Given this list of marker genes Resp18, Ybx1, Mapt, Pde1b, Ephb2, Agrp, Eno2, Bdnf, Rcvrn, Btd, Ptger4, Fmr1, Kcnn4, Homer2, Hspa1b, Plxnd1, Pink1, Igsf9b, Sncb (NCBI Gene Id 98433), Gabbr1, Crhbp, Rogdi, Lypd6, Htr1a, Hnrnpa2b1, Slc6a6, Tac1, Rab5a, Dynlt1c, Rapgef3, Rheb, Htt (NCBI Gene Id 319350), Ctnnd2, Wdr47, Psen1, Syn1 (synapsin I), Siah2, Tiam2, Lrrk2, Kcne3, Brinp1, Hspa8, Actg2, Nr1d1 (nuclear receptor subfamily 1, group D, member 1), Adam10, Gnb1, Cacna1d (NCBI Gene Id 97919), Hcn2, Lsm1, Dip2b, Rasgrf1, Kcnd3, Th (tyrosine hydroxylase, NCBI Gene Id 21823), Eef1a2, Atp6ap2, Erbb4, Mapk8 (mitogen-activated protein kinase 8), Dab1, Ror2, Rufy3, Nap1l4, Mrgpra3, Lamp1, Entpd1, Mtor, Ret, Ngfr, Nefh, Gap43, Zfp385a, Magohb, Pcsk5, Ccng1, Timp2 (tissue inhibitor of metalloproteinase 2), Calca, Kiss1, Grik3, Myo6, Rbp1, Mast1, Ptprz1, Cct4 (NCBI Gene Id 97705), Canx, Wnk4, Cnnm1, Pgrmc1, Lrit3, Rbm8a2, Entpd2, Ass1 (NCBI Gene Id 11898), Cobl, Arpc2, Trpm4, Ntrk1 (NCBI Gene Id 97088), Sh3glb1, Map2k1, Dbn1, Zpbp, Serpine2, Glrx, Enpp1, Glra3, Rack1, Flnb, Ykt6, Ckap5, Clcn2, Apod, P2rx4 (NCBI Gene Id 52272), Slc12a2, Tmem266, Aif1, Ckb, Prkca, Ppargc1a, Gpm6a, Adrb2, Septin4, Atp2b1, Brinp2 (bone morphogenic protein/retinoic acid inducible neural-specific 2), Nlgn3, Tnn, Bace1, Hpca, Gabra5, Epha7, Luzp1, Whrn, Eif5a, Ncam1, Gdi1, Atp1a2, Rbfox3, Atp5mc1, Tpx2, Dynlt1f, Shank2, Srcin1, Slc1a3, Adra2a, Syt11 (NCBI Gene Id 99745), Grm8, Myo10, Gnao1, Cyp19a1, Tlr2, Grik1, Cabp1, Sdc2, Fadd, Snap47, Htr2b, Camk2a, Adora1, Astn2, Kcnc1, Rtn4rl1, Ptpn5, C9orf72, Kif3a, Amfr, Grin3b, Ncdn (NCBI Gene Id 94325), Mbp, Pard3, Lrp4, Snap25, Syt4, Unc5c, Alcam, Nrg1, Hsp90aa1, Crhr2, Gabarapl1, C4b, Cacna1a, Cplx2, Gria1, Gria4, mt-Nd1, Pitpnm3, Ghrh, Drd1, Pnmt, Slc18a2, Kcnk1, Scn1b, Aurka, Slc5a7, Cd200, Gip, Pura, Chrm2, Ntsr1, Rps6-ps4, Ppp5c, Khsrp, Acvrl1, Fzd5, Ubxn1, Pebp1, Acan, Arg1, Cplx1, P2rx7, Ccl2, Kdr, Cacna1e, Cyp11a1, Erbb3, Ezr, Gper1 (NCBI Gene Id 76854), Pmm2, Zpbp2, Cryab, Atp1a3, Rpl28, App, Slc17a8, Klhl1 (kelch-like 1), Rab17 (RAB17, member RAS oncogene family), Katnb1, Elavl4, Igf1, Lrp6, Ptprk, Cnn3, Slc2a13, Ltbp1, P2ry12, Stau1, Rab8a, Pjvk, Nrsn1, Eif4a3, Cpne6, Dlg2, Ang, Psd2, Cit, Txn2, Polr2m, Nrxn1, Slc4a8, Casr, Dixdc1, Slc12a5, Mme, Fbxo31, Dvl1, Rgs7bp, Fbxw11, Ttll7, Dhodh, Podxl, Adam21, Hspa1l, Rab1a, Hcfc1, Cnksr2, S100a5, Slc22a3, Nradd, Pafah1b1, Adcy8, Skor1, Nmnat3, Actc1, Bmpr1b, Pcsk1, Neo1, Cfl1, Gsto1, Slc25a27, Vps35, Sv2a, Slc31a1, Rit2, Cacybp, Gsk3b, Dpp6, Gnas, Inpp5f, Snph, Prph, Htr3b, Gria2, Gal, Gigyf2, Srd5a1, Rpsa, Glrx2, Itga1 (NCBI Gene Id 320601), Atp2b2, Grin2b, Naip2 (NLR family, apoptosis inhibitory protein 2), Atxn10, Ptprn, Tmem132e, Pde1a, Cck, Ccr1, Tnk2, Kcnq3, Golga2, Cask, Slc1a1 (NCBI Gene Id 319379), Dync1h1, Pdpk1 (3-phosphoinositide dependent protein kinase 1), Cacng7, Gnb4, Ghr, Zpr1, Evx1, Nrsn2, Sncg, Rab2a, Unc5a (unc-5 netrin receptor A), Frmd7, Gfap, Cygb, Als2, Tgfb2, Rhoa, Creb3, Dpysl2, Kcnip1, Serpinf1, Rgs12, Sptbn2, Napepld, Rlbp1, Reln, Kcnd2, Cd40lg, Casp8, Esr2, Eif4b, Asl (NCBI Gene Id 76802), Kncn, Vps16, Kcnj14, Sema4f, Rapgef4, Epm2a (NCBI Gene Id 380675), Vti1b, Ppp1r9b, Ndufs7, Prkar2b, Map1a, Calcr, Fas, Tubb4a, Kcnq1, Chrna5, Hdac6 (histone deacetylase 6), Map1lc3b, Tiam1, Glrx5, Atp13a2, Pmm1, Met, Syt7, Apc, Strn3, Klc1, Azin2, Gnb2, Txnrd2, Rapgef2, Ptger3, Synpo, Cxadr, Htr7, Slc4a10, Ireb2, Pitpnm1, Sptbn4, Daxx, Fez1, Cript, Naip1, Thy1, Dynlt1a, Oprk1, Cd40, Kcnc2, Itga4, Nqo1, Elk1, Tmprss11c, Prkaa2, Ddn, Npy, Camk2n1, Piezo2, G3bp1, Cad, Washc5, Dbh, Cct3, Neurog1, Acot7, Snap91, Hcn1, Ptk2b, Crmp1 (collapsin response mediator protein 1), Cpe, Gad1, Sst, Cntnap3, Ric3, Dab2ip, Kcnk2, Tubb5, Naxe, Ache, Sipa1l1, Ppp1r1b, Dlgap3, Begain, Upf3b, Esr1, Ntrk2, Pard6a, Numa1, Zc4h2, Elovl5, Asic2, Hsp90ab1, Sh3gl2, Rrm1, Eif4a3l1, Gnb5, Acsl4, Fkbp4, Dcx, Vgf, P2rx3, Cntf, Il6ra, Mcrs1, Usp33, Chat, Mul1, Rtn1, Cct6a, Enc1, Brs3, Cnga4, Adam11, Mapk8ip2, Naip6, Gabrd, Ddc, Vti1a, Cacng4, Nefm, Trpc5, Trpv2, Kcnb1, Slc6a3, Septin7, Itga8, Syndig1, Lrp8, Acta2, Csnk1e, Copa, Cacna1h, Atp1b2, Sorl1, Cd200l1, Epha5, Apoe, Rpe65 (NCBI Gene Id 77818), Dscam, Serpini1, Psen2, Opn4, Smo, Nell2, Pum2, Snca, Stau2, P2rx6, Epo, Kcna1, Optn, Slc6a2, Pde9a, S100b, Gphn, Adra2c, Slc6a1, Trpm5, Inha, Aqp1, Slc3a2, Anxa3, Bsn, Atp7a, Dmwd, Gjb2, Cald1, Stmn2, Cnga2, Lzts1, Grm1, Tmem100, Insr, Map1b, Pvalb, Cst3, Cyba (NCBI Gene Id 13057), Flrt1, Crhr1, Rtn4, Cybb, Arhgef7, Map2k4, Homer1, Abl1, Mpl, Kcna2, P2ry1, Crh (corticotropin releasing hormone), Ppt1, Nts, Kndc1, Tcp1, Itpr3, Ctsl, Dynlt1b, Ercc8 (NCBI Gene Id 77046), Chrna3, Kcnj2, Shtn1, Zp3r, Htr3a, Scn1a, Grip2, Itsn1, Casp3, Cpeb1, Gria3, Kcnb2, Akap9, Ppp1ca, Hpn, Itpr1, Boc, Ntsr2, Dtnbp1, Cx3cr1, Ucn, Grik5, Apob, Endog (endonuclease G), Cx3cl1, Rin1 (NCBI Gene Id 225870), Comt, Ager, Lrp1, Amigo1, Cacna1b (calcium channel, voltage-dependent, N type, alpha 1B subunit), Mapk8ip3, Dennd1a, Slc38a2, Mgat5, Gnrh1, Picalm, Brd1, Got2 (glutamatic-oxaloacetic transaminase 2, mitochondrial), Klhl17, Gnaq, Cadm2, Kif1a, Tsc2, Chrna7, Cct7, L1cam, Gnaz, Casp6, Rgs8, Mapk9, Xrn1, Ppp1r9a, Gdpd5 (NCBI Gene Id 233552), Dmd, Fcgr2b, Pclo, Csf1r, Drd4, Slc1a4, Gnai2, Txn1, Ptpn13, Cacna1c, Dner, Map1s, Ccr2, Dctn1, Erc2, Baiap2, Kcnn1, Pitpnm2, Slc38a7, Kalrn, Kcnh1, Klhl14, Cd3e, Pcmt1, Strn, Kcnc4, Fus, Scn8a, Kcnn3 (NCBI Gene Id 140493), Ush2a, Smurf1, Phax, Pcsk2, Cnnm4, Rbm8a, Agfg1, Glra4, Kcnab1, Ttbk1, Slit2, Eif4a3l2, Ubb, Srd5a2, Bmpr1a, Gabra6, Negr1, Dlg1, Cib1, Cct2, Cct8, Trpm7, Kcnc3, Vps13a, Kcnd1, Nppa, Syncrip, Srsf10, Epha4, Cd200l2, Flna, Slc38a1, Tbx21, Cyfip1, Anxa5, Grm5, Gnat1, Tubb3, Trak2, Mapk1, Slc8a2, Slc2a3, Pgr, Hdc, Efhc1, Exoc4, Opn1sw (opsin 1 (cone pigments), short-wave-sensitive (color blindness, tritan)), Pawr, C4a, Ermn, Fabp7, Glul, Kng1, Katna1 (katanin p60 (ATPase-containing) subunit A1), Cacna1f, Lmtk2, Sez6l2, Gad2, Crtc1, Drd2, Fev, Naip5, Zfp804a, Sez6l (seizure related 6 homolog like), Shh, Grm7, Star, Olfm1, Grip1, Sos1, Tnfrsf1b, Cnr2, Pi4k2a, Pdyn, Dnajb1, Myo5a, Smn1, Pde1c, Lpar1, Myh10, Rin3, Rgs10, Atoh7, Hcn4, Ncf1, Gjc2, Hspa5, Plxdc1, Gna12 (guanine nucleotide binding protein, alpha 12), Dgki, Penk, Adcyap1, Chrna4, Dpysl5, Capn2, Grik2, Sort1, Rap1gap, Rnf157, Sorcs2, Ighmbp2, Pals1, Dbnl, Ilk, Txnrd1, Kif5c, Cntn2, Dlg3, Fchsd1, Tmem50a, Gng3, Dpysl3, Cdk5r1, Bptf, Scn11a, Ifng, Sorbs2, Rdh5, Vim, Pam, Trhr2, Gnb3, Erbb2, Tmprss3, Tgfb3, Prkcz, Ckmt1, Cyp17a1, Srr, Kcnip4, Nucb2, Fyn, Calb1, Kng2, Hspb1, Igf1r, Gabra2, Steep1, Ascl1, Pacrg, Casp4, Efna2, Htr5a, Park7, Hip1r, Tmprss5, Bmpr2, Ubxn2a, Apbb1, Il6st, Kcnj10, Myo1d, Kif5a, Ccr4, Ulk1, Wdfy3, Nf2, Scn3a, Septin14, Dhx36, Tgfb1, Maob, Brinp3, Glra1, Grk4, P2rx2, Bglap, Kcnma1, Lnpep, Ndel1, Rac3, Sod1, Ptbp2, Hmcn2, Htr2a, Syap1, Prkn, Cct5, Ccn3, Src, Tacr1, Snx18 (sorting nexin 18), Braf, Ogt, Capzb, Tnf, Pde11a, Rtn4rl2, Mylk2, Tanc1, Pde10a, Grik4, Dlgap4, Ppp2r1a, Cfh, Pdgfb, Ada, Adcy10, Kremen1, Grin3a, Klhl24, Acta1, Rab38, Hcn3, Fubp3, Npff, Nrp1, Cdc42 (NCBI Gene Id 12540), Rptor, Drd5, Cd22, Astn1, Gfra1, Vip, Pycard (NCBI Gene Id 66824), Shroom2, Fzd3, Alk, Kcnn2, Impa1, Drp2, Adcy1, Camk2d, Prkaa1, Cacna1g, Gpc1, Rnf112, Kcnj4 (potassium inwardly-rectifying channel, subfamily J, member 4), Kcnj6, Cnga3, Sez6, Uchl1, Bglap2, Reg1, Stk39, Slc8a1, Oprm1, Npcd (NCBI Gene Id 504193), Ptprf, Hdac1, Crcp, Adora2a, Robo1 (NCBI Gene Id 436378), Plk3, Cdk5, Chrm4, Ngb, Mob4, Nrgn, Bglap3, Gabarap, Disc1, Chrna10, Kcnj12, Tacr3, Slc1a2, Grin1, Neurl1a (neuralized E3 ubiquitin protein ligase 1A), Syt5, Cntnap2, Rps6, Camk2b, Trpv1, Mapk10, Omp, Cpne5, Kif3c, Map2, Mapk8ip1, Akap12, Top1, Arhgef2, Ptges3, Sirt2, Adnp, Myo1a (NCBI Gene Id 632872), Mtnr1a, Ptprs, Kcnj11, Rtn4r, Slc8a3, Cftr, Myo5b, Nsmf, Mmp3, Igf2bp1, Slc7a10, Gripap1, Palld, Akap5, Trpm2, Pnoc, here is a description of the gene set: species: Mus musculus Mouse Gene Set: GOCC_CELL_BODY The portion of a cell bearing surface projections such as axons, dendrites, cilia, or flagella that includes the nucleus, but excludes all cell projections.